Given this list of marker genes VPS18, MGRN1, HOOK3, RAB12, ARL8B, UEVLD, RILP, VPS16, CHMP4C, CHMP6, TRAK1, LIPA, GPRASP1 (NCBI Gene Id 9737), CHMP7, UBXN6 (NCBI Gene Id 80700), CHMP4B, HOOK1, SORT1, BIN1, RAB7B, SNX16, RAB7A, AKTIP, VPS39, RUFY4, VPS4B, SNX27, CHMP5, TPCN2, VCP, SNAPIN, VPS11, PLEKHF2, HMGXB4, VPS41, VIPAS39, TSG101, CHMP2B, CHMP4A (NCBI Gene Id 338010), ADRB2, PLEKHF1, MTM1, CDX2, VAMP7, TGFBRAP1, M6PR, VPS4A, ATG14, CHMP3, VPS33B, BECN2, HOOK2, DENND3, FHIP1B, AP3D1, TRAK2, LYST, MVB12A, VPS33A, KIF13A, EPG5, CHMP1A, DTX3L, CHMP2A, RHOB, SCYL2 (NCBI Gene Id 55681), CHMP1B, PCDHGA3, here is a description of the gene set: The directed movement of substances from endosomes to lysosomes. species: Homo sapiens Human Gene Set: GOBP_ENDOSOME_TO_LYSOSOME_TRANSPORT